Given this list of marker genes ACACB, SLC7A11, GLS, GRM2, KCTD7 (NCBI Gene Id 154881), SLC1A1 (solute carrier family 1 member 1), here is a description of the gene set: A homeostatic process involved in the maintenance of a steady state level of glutamate within a cell. studied in species Homo sapiens Human Gene Set: GOBP_INTRACELLULAR_GLUTAMATE_HOMEOSTASIS